The following is a description of a gene set: Any process that results in a change in state or activity of a cell or an organism (in terms of movement, secretion, enzyme production, gene expression, etc.) as a result of a follicle-stimulating hormone stimulus. Mouse Gene Set: GOBP_RESPONSE_TO_FOLLICLE_STIMULATING_HORMONE species: Mus musculus, and this is the list of marker genes: Asns, Epha5, Pde4d (NCBI Gene Id 320753), Ednra, Gata4, Epha3, Gata1, Cyp1b1, Ghsr, Epha8, Tgfbr3, Akr1c18 (NCBI Gene Id 105349), Pappa, Edn1, Notch1, Inhba, Srd5a2, Fshr, Gclm, Ppargc1a, Efna5, Gclc, Star